Given this list of marker genes YWHAZ, VCPIP1, STK25, PDCD10, VPS13B, here is a description of the gene set: Human Gene Set: GOBP_GOLGI_REASSEMBLY studied in species Homo sapiens The reformation of the Golgi following its breakdown and partitioning contributing to Golgi inheritance.